The following is a description of a gene set: Mouse Gene Set: REACTOME_POST_NMDA_RECEPTOR_ACTIVATION_EVENTS studied in species Mus musculus Post NMDA receptor activation events, and this is the list of marker genes: Rps6ka3, Rps6ka2, Prkar1b, Camkk1, Calm2, Calm1, Rps6ka6, Calm3, Camk1, Creb1, Rps6ka1, Camkk2, Prkaca (protein kinase, cAMP dependent, catalytic, alpha), Prkar1a (NCBI Gene Id 80472), Prkacb